Given this list of marker genes NKX3-1, STRN, CNOT1, NRIP1, ZNF366, RERG (NCBI Gene Id 85004), MED1, WBP2, FOXL2, NCOA6, NCOA1, SRARP, PPID, LATS1, DNAAF4 (dynein axonemal assembly factor 4), PADI2, PPARGC1B, PCNA, PARP1, TAF10 (TATA-box binding protein associated factor 10), DCAF13, CTNNB1, ESR1, MMS19, TACC1, DCAF1, TRIP4, ISL1, CCDC62, XBP1, PAGR1, LEF1, WIPI1, NSD1, PHB2, PRMT2, LCOR, ARID5A, DDX54, here is a description of the gene set: Binding to a nuclear estrogen receptor. Human Gene Set: GOMF_NUCLEAR_ESTROGEN_RECEPTOR_BINDING studied in species Homo sapiens